Given this list of marker genes Stat5a, Il2rg, Il9, Jak3, Jak1, Cited1, Stat3, Il9r, Stat1, here is a description of the gene set: Any process that results in a change in state or activity of a cell or an organism (in terms of movement, secretion, enzyme production, gene expression, etc.) as a result of an interleukin-9 stimulus. Mouse Gene Set: GOBP_RESPONSE_TO_INTERLEUKIN_9 species: Mus musculus